The following is a description of a gene set: We combined large-scale mRNA expression analysis and gene mapping to identify genes and loci that control hematopoietic stem cell (HSC) function. We measured mRNA expression levels in purified HSCs isolated from a panel of densely genotyped recombinant inbred mouse strains. We mapped quantitative trait loci (QTLs) associated with variation in expression of thousands of transcripts. By comparing the physical transcript position with the location of the controlling QTL, we identified polymorphic cis-acting stem cell genes. We also identified multiple trans-acting control loci that modify expression of large numbers of genes. These groups of coregulated transcripts identify pathways that specify variation in stem cells. We illustrate this concept with the identification of candidate genes involved with HSC turnover. We compared expression QTLs in HSCs and brain from the same mice and identified both shared and tissue-specific QTLs. Our data are accessible through WebQTL, a web-based interface that allows custom genetic linkage analysis and identification of coregulated transcripts. from publication Bystrykh L, Weersing E, Dontje B, Sutton S, Pletcher MT, Wiltshire T, Su AI, Vellenga E, Wang J, Manly KF, Lu L, Chesler EJ, Alberts R, Jansen RC, Williams RW, Cooke MP, de Haan G (PMID 15711547) studied in species Mus musculus Human Gene Set: BYSTRYKH_HEMATOPOIESIS_STEM_CELL_RUNX1 Genes whose expression is coregulated with that of RUNX1 in hematopoietic stem cells (HSC)., and this is the list of marker genes: PHOX2B, CD55, ACVRL1, EPHB3, IL12RB2, PRSS2, CSF3R, PGR